Given this list of marker genes ADGRL3, CABP7, C1QTNF3-AMACR, PLAT, SRGAP2 (SLIT-ROBO Rho GTPase activating protein 2), TPTE, HES1, DGAT2, SCARNA12 (NCBI Gene Id 677777), FAM131B, NRP1, LRRC45, PDCD6 (programmed cell death 6), PCLO, CCND1, PIK3R3, HOXD8, SNHG11, PDGFC, ZNF608, TMEM107, SHOC1, TMEM25, HOXB9, RPP25L, BHLHE40, KIFC2, AGRN, MAP3K12, SLX1A, PLK3, TANC1, LINC01138, CTDSP1, VARS2, EFHC1, ARRDC3, MAF, KLF6, PARP8, PSME1, FANCG, GAS5, SNHG10, DLC1, DHRS3, LINC01003, AMDHD2, HOXB-AS3, SESN1, A1BG, HOXB6, PIDD1, EPHA4, TNRC18, LYPD1, PVT1, SNHG32, MSH5-SAPCD1, NDRG2, HMGB2, PBXIP1, ST6GALNAC6, POLL, NOG, UBE2QL1, ARHGAP5-AS1, TPM1, HMG20B, FHL1, PNRC1, SNORA63, PAXX, TGIF1, AMACR, WDR54, LINC00623, RIN1, MOXD1, LINC02315, CCN1, GDF15, BARD1, FN1, H1-0, C19orf48P, NPRL2, PMM1, GPR39, KLHL24, KLF7, PDE5A, SNORA70, TRPT1, CADM1, KLF3, SSBP4, CITED2, SNORA73A, SNORD51, SNORA10 (NCBI Gene Id 574042), GLI1, ARHGAP10, H2AC7, TRO (NCBI Gene Id 7216), LIG1, DPP7, SSBP2, KCNH3, MECOM, RNF215, PPM1M, SOX4, PRICKLE1 (NCBI Gene Id 144165), KLF9, TCF4, NT5C, NAT9, NME3, FZD4, CXXC4, SCD5, DDB2, TRHDE-AS1, RGS10, SMOC1, ENC1, SNORA64, OXLD1, CACNB1, SRGAP2B, TRAIP, FLOT1, DDIT4, HOXC9, SPSB3, ANKRD36B, BCOR, LMO4, RARB, JUND, SNORA21, COMTD1, ENSG00000289047, PLEKHH3, PLXNB1, CHASERR, UBE2E1, PHLDB2, CYBC1, RECQL4, DOCK4, PIGQ, FSTL3, SLC35E2B, SSH3, SERTAD4, SMUG1, HOXB3, DACT1, FCSK, VIM (vimentin), SOX12, RCOR3, NPHP4, PARD6A, ETV1 (ETS variant transcription factor 1), here is a description of the gene set: Human Gene Set: IBRAHIM_NRF1_DOWN studied in species Homo sapiens Genes down-regulated in HEK293T cells overexpressing FLAG-NRF1 The NRF transcription factors NRF1, NRF2, and NRF3, are a subset of Cap'n'collar transcriptional regulators which modulate the expression of genes harboring antioxidant-response element (ARE) sequences within their genomic loci. Despite the emerging physiological importance of NRF family members, the repertoire of their genetic targets remains incompletely defined. Here we use RNA-sequencing-based transcriptional profiling and quantitative proteomics to delineate the overlapping and differential genetic programs effected by the three NRF transcription factors. Comparing our data to recent profiling analyses, we create consensus target gene sets regulated by NRF1, NRF2, and NRF3, genetic programs which we determine to be differentially regulated in human tissues. Together, our data provide a quantitative assessment of how NRF family members sculpt proteomes and transcriptomes, essential information for future studies evaluating the role of NRF factors in normal physiology and disease. from publication Ibrahim L, Mesgarzadeh J, Xu I, Powers ET, Wiseman RL, Bollong MJ (PMID 33096892)